Given this list of marker genes Septin5 (septin 5), Camk2a, Ncam1, Stxbp1, Ralb, here is a description of the gene set: Any process that modulates the frequency, rate or extent of vesicle docking. species: Mus musculus Mouse Gene Set: GOBP_REGULATION_OF_VESICLE_DOCKING